Given this list of marker genes FGF13, ADGRV1, DNM1, STX1B, CLN6, CHD2, ADORA2A, POLG, SCN9A, PCDH19 (NCBI Gene Id 89774), CDKN2C, CDKN1B, GRIN2A, ODC1, MEN1, HNRNPU, GABRA1, SLC1A2, CDKN2B, SCN1B, GABRG2, SCN1A, GABRD, CDKN1A, PRRT2, HCN1, SCN2A, here is a description of the gene set: species: Homo sapiens Human Gene Set: HP_STATUS_EPILEPTICUS_WITHOUT_PROMINENT_MOTOR_SYMPTOMS Status epilepticus without prominent motor symptoms There is inconclusive evidence to precisely define the duration of the seizure; however, based on current evidence an operational threshold of 10 minutes is appropriate as beyond this a seizure is likely to be more prolonged. The individual may or may not be aware or in coma.